Given this list of marker genes Ifi203, Plekhh1, Snx15, Irs4, Zzef1, Mospd2, Mecp2, Lrrc41, Septin1, Mei1, Fam168a, Lmf2, Slc44a5, Asic2, H2ax, Zfp704, Zfp11, Kalrn, Phb1, Alk, 1110004F10Rik, Picalm, Brsk1, Slc25a27, Clec4a2, Syngr3, Sgcd (NCBI Gene Id 24052), Camsap1, Eif4e1b, Gna13, Rgs13, here is a description of the gene set: Genes predicted to be targets of miRBase v22 microRNA mmu_miR_6396 in miRDB v6.0 with MirTarget v4 prediction scores > 80 (high confidence targets). studied in species Mus musculus Mouse Gene Set: MIR_6396 from publication Chen Y, Wang X (PMID 31504780)